Given this list of marker genes CNOT2, PLAG1, TNFRSF19, HIGD1A (HIG1 hypoxia inducible domain family member 1A), NCBP3, HECW1, RFX7, LCOR, SBNO1, ATG12, STRIP1, PDSS2, RNF19A, DCP1A, ERLIN1, AMMECR1, SFRP1, PDS5B, DICER1, RNF8, CDC25A, ALDH1A3, AARS1 (alanyl-tRNA synthetase 1), GPC6, PSD3, MAF1 (NCBI Gene Id 84232), KCND1, ADGRB3 (NCBI Gene Id 9664), SMG5, MAML1, DHX58, WSB1, TMEM62, ZNF880, SUFU, KAZN, C6orf62, ARHGAP17, UBE2D4, CASP3, APPL1, MBNL3 (muscleblind like splicing regulator 3), SV2C, NFIB, IL16, RNF11 (NCBI Gene Id 26994), EVC2, B3GALT4, MDGA1, GGA2, CDK17, SLC66A2, FAM78A, DLG2, KRI1, TTYH2, CCDC85C (NCBI Gene Id 64758), SP1 (Sp1 transcription factor), VDAC2, SNX8, PDS5A, EXOC6B, INO80D, MAP1B, MBTD1, SIX4, DNAJC6, ENPP2, SETD3, RABL3, CFAP77, MAP9, MAFG, FZD4 (frizzled class receptor 4), TTLL7, FLCN, ICE1, TNPO1, KMT2C, RASL12, ARMC8, KIFAP3, CALN1, BCL2L11, RAB11FIP2, ANK1, ALKBH5, TDG, NPAS3, SATB2, OLFM1, MMP24, RAI14, FAM217B, ORAI2, RAB1A, SYT11, CPEB3, HACD2, TPP1, PARD3B, KAT7, PATE4, CAMK2G, HLTF, HSPA12A, MEF2D, HEY2, MRPL48, PTCHD1, ADAM7, GPCPD1, CTNND1, EPS15L1, NTNG1, ADARB2, ATXN1L, POLDIP2, SMARCE1, KCNJ3, TOLLIP, UNC119B, MECP2, MAP4K3, CHD2, NUDT13, IMPDH1, PPP4R3A, CFAP161, STAT3, TNNT3, ASTN1, AGFG1, S1PR3, KCTD9, PLAGL2, PIF1, HPCAL4, PRRC2B, UBE2W, NR1D2, NQO1, PSMF1, AJUBA, DENND5A, ZBTB46, POLA2, SLC35A3, CBR1, SCN7A (sodium voltage-gated channel alpha subunit 7), SEPTIN5, COX15, VAV3 (vav guanine nucleotide exchange factor 3), DFFA, AGO1, SNTG2, KIAA0513, FAM98A, DPYSL2, CHRDL1, TBCEL, FOXP1, TMEM200B, MAP6, here is a description of the gene set: Human Gene Set: MIR1184 from publication Chen Y, Wang X (PMID 31504780) studied in species Homo sapiens Genes predicted to be targets of miRBase v22 microRNA hsa-miR-1184 in miRDB v6.0 with MirTarget v4 prediction scores > 80 (high confidence targets).